The following is a description of a gene set: from publication Hammer M, Mages J, Dietrich H, Servatius A, Howells N, Cato AC, Lang R (PMID 16380512) Activation of the Mitogen activated protein kinase (MAPK) cascade following Toll-like receptor (TLR) stimulation enables innate immune cells to rapidly activate cytokine gene expression. A balanced response to signals of infectious danger requires that cellular activation is transient. Here, we identify the MAPK phosphatase Dual specificity phosphatase-1 (DUSP1) as an essential endogenous regulator of the inflammatory response to LPS. DUSP1-deficient (DUSP1-/-) bone marrow derived macrophages showed selectively prolonged activation of p38 MAPK and increased cytokine production. Intraperitoneal challenge of DUSP1-/- mice with LPS caused increased lethality and overshooting production of IL-6 and TNF-alpha. Transcriptional profiling revealed that DUSP1 controls a significant fraction of LPS-induced genes, that includes IL-6 and IL-10 as well as the chemokines CCL3, CCL4 and CXCL2. In contrast, the expression of the important mediators of endotoxin lethality, IFN-gamma and IL-12, was not significantly altered by the absence of DUSP1. These data together demonstrate a specific regulatory role of DUSP1 in controlling a subset of LPS-induced genes that determines the outcome of endotoxin shock. Genes up-regulated in spleen from wildtype mice: control versus LPS. Human Gene Set: GSE3565_CTRL_VS_LPS_INJECTED_SPLENOCYTES_UP species: Homo sapiens, and this is the list of marker genes: SLC2A3, SEMA4F, BMPR1A, LPIN1, SH3BGRL, CLDN20, IL18RAP, CCDC50, MEF2A, ZDHHC2, GALNT3, EEA1, ITGAL, CD44, ELL2, TBX21, DUSP3, RPA2, SMAD3, ZFAND4 (zinc finger AN1-type containing 4), HIP1, NRP1, CYP17A1, DIPK2A, GNA15, SMYD1, CFAP126, HCST, IL15, ATP2B4, CALM2, PRKAR2A, PFKP, EBPL, ID2, STARD10, PIK3CG, PRDM1, PRF1, RNF19B, LONRF3, MYO1F, ERN1, PPT1, RORA, SRP68, EMP3, LATS2, BCL2L1 (NCBI Gene Id 598), MYLIP, CCDC146, ATP6V0D2, SOS2, DGKH, MAPKAPK3, SMPDL3B, XDH, SRCIN1, HAVCR2, ANKS3, ALCAM, S1PR5, GSAP, TTC39C, CTSD, CCL5, PCGF2, ITGA1, DOCK5, CD48, NSD2, UPK1A, IL18R1, POLK, B4GALT5, TSPAN2, KLRC3, ITGB1, ANXA2, MYADM, OSBPL3 (oxysterol binding protein like 3), FCGR2B, RNF216 (ring finger protein 216), GPRIN3, L1CAM, S100A6, IL7R, CX3CR1, GABBR1, CORO2A, PTPN22, ARMC7, CD226, ARHGAP18 (NCBI Gene Id 93663), NT5E, ITGAM, GZMM, IL12RB2, DAPK2, BHLHE40, IL1RL1, CD80, TNFRSF1B, SLCO3A1, PIK3R5, LRRK1, CHPT1, KLRC2, SOAT2, IFNG, GZMK, HOPX (HOP homeobox), SPN, OSTF1, PTPRJ, CXCR6, COBLL1, ITGB2, NRBP1, F2RL2, CLIC4, ESM1, CYFIP1, EMP1, GNPTAB, EHBP1L1, TUG1, SLC20A1, LITAF, MYO5A, AAK1, TEF, RUNX1 (RUNX family transcription factor 1), CMKLR1, TASL, HDHD5, ZEB2, CCR2, CHIC1, DMRTA1, SYTL2 (NCBI Gene Id 84564), MARCHF3 (membrane associated ring-CH-type finger 3), ITGAX, KLRK1, KIF5C, PIK3AP1, SLC4A7, CISH, PLEKHM3, NDNF, ATP2B1 (NCBI Gene Id 490), KCNJ8, UBXN2B, LGALS3, GVINP1, NKG7, PCYT1A, ATXN1, SNX10, ITGA4, PRDX4, HLA-B, ENTPD1, AHNAK (NCBI Gene Id 79026), IL2RA, RGS1, TTC7B, S100A10, NEBL, LAIR1, H2AZ1, UBA6, PTPN13 (protein tyrosine phosphatase non-receptor type 13), BORCS7, TTC39B, TMEM163, RUNX2, ANXA1